Given this list of marker genes Bco2, Aldh1a3, Sdr16c5, Aldh8a1, Abca4, Rdh11, Dhrs4, Rpe65, Cyp1b1, Rdh10 (NCBI Gene Id 98711), Akr1c18, Rbp4, Bco1, Rdh13, Aldh1a2, here is a description of the gene set: The chemical reactions and pathways involving retinal, a compound that plays an important role in the visual process in most vertebrates. In the retina, retinal combines with opsins to form visual pigments. Retinal is one of the forms of vitamin A. studied in species Mus musculus Mouse Gene Set: GOBP_RETINAL_METABOLIC_PROCESS